Given this list of marker genes Unc5c, Unc5a, Unc5cl, Dcc, Unc5d, Unc5b, here is a description of the gene set: Combining with a netrin signal and transmitting the signal from one side of the membrane to the other to initiate a change in cell activity. species: Mus musculus Mouse Gene Set: GOMF_NETRIN_RECEPTOR_ACTIVITY